Given this list of marker genes Dctn6, Fgd4 (FYVE, RhoGEF and PH domain containing 4), Hip1, Myo5b, Rasa1, Daam2, Cenph, Spta1, Plek2, Iqgap3, Macf1, Myoz2, Dvl1, Rapgef3, Ulk4, Arhgef5, Drg1, Ablim2, Dicer1, Pfdn1, Plekhh2, Krt33b, Grid2ip, Odad2, Myo1h, Cdc42bpb (NCBI Gene Id 93839), Dpysl2, Tln1, Agfg1, Flg, Dnal1, Mlst8, Pak1, Bcas3, Marcksl1, Kif3a, Krt23, Evl, Tubgcp2, Tbce, Arhgef10l, Zmym6, Nefm, Epha1, Mast1, Kif15, Sh3d19, Kank4, Agfg2, Nherf1, Jhy, Mcph1, Ttll6, Gas8, Bcl2l10, Haus8, Coro6, Map3k1, Brca1, Nectin2, Gan, Csf1r, Slc4a2, Cttnbp2, Lrrc23, Kiz, Bora, Map6d1, Nes, Actr3, Krt4, Thsd7a, Bbln, Kif2a, 4933427D14Rik, Cetn4, Lpar1, Tpm3-rs7, Obsl1, Stradb, Csf3, Arhgef17, Vim, Cdc42ep3, Cfap73, Atxn7, Pakap, Fgd1, Hepacam2, Cenpa, Brca2, Cep20, Ska1, Bcl6, Baiap2, Rsph6a, Meig1, Epb41l5, Sirt1, Efna5, Arrb1, Nme7, Dsp, Map1b, Cfap58, Cplane2, Ift88, Odam, Cdc20, Kash5, Cav1, Crk, Daw1 (dynein assembly factor with WDR repeat domains 1), Mei1, Kank2 (KN motif and ankyrin repeat domains 2), Eml3, Espnl, Srcin1, Id1 (inhibitor of DNA binding 1, HLH protein, NCBI Gene Id 98917), Ndc80, Fmnl2, Llgl2, Pxn, Dnaaf10, Capzb, Mtor, Lrch3, Uxt (NCBI Gene Id 319632), Haus5, Pex14, Stard8, Tubgcp6, Neb, Ccl24, Des, Epb41l4a, Arap3, Baiap2l2, Tuba1a, Limk1, Inpp5j, Eml1 (NCBI Gene Id 68519), Eps8, Pycard, Washc4, Stag2, Npm1, Ssh1, Fermt2, Sgo1, Mybph, Krt10, Actr2, Odf2, Tekt2, Pfdn2, Cdc14a, Prickle1, Antxr1, Smad4, Fchsd1, Rock2, Myo18b, Carmil1, Eef2k, Atat1, Fam107a, Rcc1, Lima1, Ccl12, Plk3, Shroom2, Tacstd2, Chd3, Gdpd2, Ccdc57, Rnd2, Rtkn, Hcls1, Srgap2, Dnaaf6rt (dynein axonemal assembly factor 6, retrotransposed), Gabarap, Rhobtb1, Htt, Ccdc61, S1pr2, Gm6176, Ttll5, Tenm1, Mapt, Mrtfa, Spata4, Arhgap17, Sptb (NCBI Gene Id 383567), Il1a, Tubgcp4, Dnaaf6 (dynein axonemal assembly factor 6), Sun1, Nckap5, Dlgap5, Myl9, Gm6882 (NCBI Gene Id 628475), Sh3gl2, Xpo1, Pls1, Chek1, Krt34, Arhgef10, Arhgap6, Pfn2, Krt26, Akap11, Pkp1, Kif20a, Poc5, Grhl3, Nebl, Pdgfrb, Prkn, Calml4, Naa20, Pof1b, Dsg3, Map3k20, Pierce1, Cfap44, Pla2g3, Fgf10, Pard3b, Lrrc61, Dnaaf11, Ccl7, Krt81, Lix1l, Ccn2, Auts2, Cx3cl1, Hsp90b1, Pdcl3, Ssh3, Spry2, Cdc42bpg, Fscn3, Casp4, Klhl24, Fgf7, Cc2d2a, Kank3, Tesk2, Cep250, Bag4, Elmod3, Hook2, Cryaa, Cep192, Tubb3, Strip2, Epb41l1, Bmerb1, Ccdc13, Cxadr, Smc3 (structural maintenance of chromosomes 3), Aqp2, Dmtn, Tuba1c, Myo1b (myosin IB), Prkaa2, 4930544G11Rik, Snx9, Tgfb1, Efhc1, Syne2, Nlrp5, Elmo1, Cdc42bpa, Ptk7, Add1, Epb41, Sh3pxd2b, Cd47, Mzt1, Myh11, Klhl41, Ablim3, Tnik, Actn1, Fgd2, Sik3, Dnai1, Chmp1b, Krt5, Sprr1b, Ccdc120, Larp4, Nudc, Cep19, Uvrag, Fam171a1, Fhdc1 (NCBI Gene Id 229474), Cflar, Icam1, Tsc1, Tubb5, Ptger4, Lrguk, Krt12, Ywhah, Diaph1, Whamm, Pik3r1, Gnai1, Chmp7, Map4, Taok2, Sapcd2, Stmn1, Abi2, Kirrel1, Abraxas2, Nav3, Amotl2, Capg, Fhod1, Lmod3, Ccnl1, Ccdc15, Ccdc40 (coiled-coil domain containing 40), Tchh, Diaph2, Cpne6, Cyfip2, Ccdc66, Akt1, Pik3r2, Tacc1, Sun2, Specc1l, Syde1, Raf1, Plekhg2, Gadd45a, Magel2, Tubal3, Mos, Crhr2, Krt13, Mypn, Ccdc39, Poldip2, Hook3, Tnnt3, Ccnl2, Dnaaf1, Cep43, P2rx7, Aqp1, Zmym4, Cep63, Dnaaf5, Nf2, Arhgef18, Gtf2b, Sprr2a1, Wnt4, Cfap74, Tubb1, Cc2d1a, Myo1a, Trdn, Smn1, Wipf3, Myo19, Cap2, Ccnb2, Dpysl3, Hmcn1, Hsph1, Ccnb1, Cdc42ep1, Rgs4, Krt42, Cenatac, Trpv4, Nlrp4f, Luzp1, Spag1, Tjp1, Rhoc, Krt82, Krt86, Gm14137, Krt71, Plk5, Cap1, Ngef, Arfip2, Syne3 (spectrin repeat containing, nuclear envelope family member 3), Emp2, Stmn2, Fbxw5, Gpr65, Epha3, Gja1, Phldb2, Naa25, Msrb1, Ppfia1, Lrrc46, Diaph3, Prr5, Ska2, Axin1, Jmy, Abraxas1, Cfap206, Pdgfa (platelet derived growth factor, alpha), Cfap100 (NCBI Gene Id 77534), Elmo2, Parvb, Phactr2, Abra, Arfgef1, Knstrn, Phip, Arhgap12, Tmod2, Mtm1, Mical3, Tgfbr1, Spata7, Kif2c, Mylk3, Map7d2, Cdc20b, Mdk, Myo7a, Krt39, Spaca9, Dnai3, Atf5, Frmd5, Katnal2, Ino80, Poc1b, Map7d1, Rnf4, Iqsec1, Mapre3, Hras, Plek, Stau2, Sptbn1, Krt78, Pacsin1, Fhod3, Trf, Cln3, Limd2, Eml4, Prune1, Brsk1, Tppp, Mybl2, Wipf1, Pkp2, Casq1 (NCBI Gene Id 12372), Apc, Krt17 (NCBI Gene Id 16667), Ntmt1, Ckap2, Ubxn2b, Ttll8, Ankfn1, Tacr1 (NCBI Gene Id 21336, tachykinin receptor 1), Krt28, Smad3, Wee1, Rac1, Haus2, Atp2c1, Swap70, Slc39a12, Arpc1a, Kifc5b, Limd1, Cep44, Prex1, Nuak2, Arc, Ccl21a, Rap1gds1, Armc2, Tppp3, Ccr7, Baiap2l1, Cdk11b, Cdk2ap2, Chmp1b2, Cep85, Cfap91, Mid1ip1, Hnrnpu, Zmym3, Dst, Thy1, Nsfl1c, Zfp207, Frmd7, Pafah1b1, Cep126, Cdc42ep5, Cgnl1, Wtip, Ttc8, Cltc, Abi3, Agap2, Tmeff2, Ift56, Iqgap1, Csnk1a1, Prkcd, Akap9, Incenp, Cep295nl, Gas2, Specc1, Myo3a, Ttll11, Arhgef19, Epb41l2, Atxn3, Prkce, Pacsin3, Dnai4, Ect2, Myo1f, Kit, Ikbkb, Brsk2, Xirp2 (xin actin-binding repeat containing 2), Septin7, Ttll2, Cdc14b, Arpin, Rictor, Cul7, Wasl, Afg2b, Nefh, Cenpe, Pard6g, S1pr1, Bnip2, Krt74, Ctnnb1 (NCBI Gene Id 12387), Samd14, Zyx, Nckap1, Bcar1, Clasp2, Golga2, Rala, Zranb1 (NCBI Gene Id 77556), Cryab, Apc2, Git1, Kif21a, Myo6, Snupn, Itgb1bp1, Dnah5, Krt7, Pkp3, Wnt11, Pam, Krt25, Eppk1, Washc5, Limk2, Atp8a2 (NCBI Gene Id 50769), Krt72, Tubd1, Pard6a, Ccdc68, Tmem67 (NCBI Gene Id 76678), Scin, Clasp1, Pak5, Map7, Cldn3, Rhoq, Itgb3, Wmp, Wnt3a, Mast2, Bcr, Kras, Kif11, Plec, Bfsp1 (NCBI Gene Id 277454), Adgrb1, Nphs2, Zw10, Tbc1d32, Cald1, Cavin3, Zmynd12, Crocc, Ccdc69 (coiled-coil domain containing 69), Gapdhrt2 (glyceraldehyde-3-phosphate dehydrogenase, retrotransposed 2), Cracd, Myom1, Pak3, Cep290, Flnc, Ak7, Wasf1, Xrcc2, Sirpa, Krt40, Dag1, Pard6b, Pkhd1, Togaram1, Ripor2, Kif3b, Katnbl1, Sass6, Enkd1, Arpc1b, Nisch, Ppm1f, S100a10, Tbck, Mfn2, Stag1, Mast3, Cetn2, D7Ertd443e, Arpc5l, Kat2a, Chordc1, Gm10668, Mkks, Spice1, Mapk15, Kat5, Lurap1, Capn6, Prkar1a, Carmil3, Pawr, Prkcz, Pax6, Nedd9, Epha5, Cep120, Sbds, Arf6 (NCBI Gene Id 11845), Arap1, Spast, Flii, Ttll9, Actb (actin, beta), Arhgap35, Rufy3, Sh2b2, Eml2, Inf2, Prph, Ooep, Sugt1, Dcx, Tuba3a, Cdk5r1, Ccdc42, Mtpn, Capn1, Dixdc1, Pierce2, Son, Kiss1r, Dync1li2, Gda, Aurkc, Myh14, Pdlim3, Nexn, Spatc1l, Ccl21d, Apoa1, Znrf1, Enah, Mef2c (myocyte enhancer factor 2C), Jam3, Kifbp, Gm5478 (predicted pseudogene 5478), Cfap43, Lzts2, Poc1a, Sh3bgrl3, Myh9, Arhgef1, Arhgef16, Mns1, Mapre2, Catip, Nup62, Svil, Gapdhrt, Clip2, Gas2l2 (NCBI Gene Id 278498), Bcl2, Actn2, Spire2, Prpf40a, Was, Atrx, Sac3d1, Dynlt1f, Cfap65, Anxa1 (annexin A1), Lmod1, E2f4, Fsip1, Cfap410, Cep135, Capza1b, Shank3 (NCBI Gene Id 58234), Ttl, Capza2, Arap2, Adprhl1, Numa1, Slc16a1, Fbxo5, Rae1 (NCBI Gene Id 66679), Trim37, Tspan32, Cav3, Kank1, Hck, Tacc3 (transforming, acidic coiled-coil containing protein 3), Arhgap25, Actn4, Fhl3, Ush1c, Kifc1, Cript, Arhgap40, Prkcq, Fgr, Cul9, Pfn1, Tesk1, Cntln, Phldb1, Gmfb, Add3 (adducin 3), Abl2, Edn1, Sfrp1 (NCBI Gene Id 72362), Ska3, Nat10, Tacc2, Lsm14a, Rp1, Capn10, Chmp2b, Fgf13, Pgm5, Cdk10, Sorbs1, Atf2, Cep295, Odad1, Hook1, Cavin4, Spef2, Zbed3, Septin1, Spc25, Zpr1, Arf1, Fitm2, Ppl, Gm10662, Ttll7, Myo7b, Dnah7c, Cdk1, Cetn1, Kif18a, Cyld, Chmp4c, Palld, Ccdc187, Cgn, Wasf2, Mecp2, Ube2b, Krt36, Wdr47, Lpin1 (NCBI Gene Id 50494), Rhov, Nusap1, Msrb2, Nde1, Bcas2 (NCBI Gene Id 99556), Inpp5k, Fkbp4, Smc1a, Tnfaip1, Cep152, Llgl1, Dnaaf4, Ezr, Pdxp, Abr, Map2, Large1, Usp33, Nox4, Sod1, Tubg1, Limch1, Haus4, Rps3, Map7d3 (NCBI Gene Id 320923), Cep131, Tube1, Arhgef15, Itgb1, Misp, Sema5a, Pmp22, Padi6, Tnf, Lmna, Cnn2, Ccl26 (NCBI Gene Id 541307), Fam83h, Ccser2, Micall2, Cd2ap, Arfip1, Pten, Pdgfra, Stmn3, Twf2 (twinfilin actin binding protein 2), Cntrob, Pkd1, Tpm3, Amot, Avil, Dstn, Nkx2-5, Fscn1 (fascin actin-bundling protein 1), Ccdc78 (NCBI Gene Id 381146), Actc1, Aif1, Gsk3b, Cntn2, Krt35, Mlh1, Phactr3, Fgd3, Fbxo24, Rhob, Fscn2, Krt77, Dnah7a, Maea, Cldn19, Ccl21b, Sox9, Tubgcp3, Tlr2, Pclo, Myo5a, Mapk1, Itpka, Fzd10, Vil1, Cln8, Krt84, Dctn2, Ints13, Cep72, Dnah8, Ccdc88a (NCBI Gene Id 77927), Tmsb15b2, Ehd2, Mir129-2, Pdzd8, Pcm1, Cdk5r2, Spag17, Arpc5, Parvg, Celsr1, Haus7, Trpm7, Rhoa, Rab13, Farp1, Tmod1, Serpinf2, Slain2, Ugt8a, Setd3, Cdc42ep2, C2cd3, Ablim1, Stmn4, Ppp2r1b, Pdcl2, Cep70, Synpo2l, Myo1c, Nlgn1, Tuba4a, Synpo2, Cul3, Mark2, Sdccag8, Cntnap1, Bbs1, Esam, Odad3, Calm4, Nck1, Pdlim4, Gpsm1, Kif23, Kif4, Mtcl1, Stk36, Gcc2, Pip5k1a, Neurl2, Senp6, Myh10, Rhog, Cfap157, Ssx2ip, Krt6a, Agrn, Ccl27a, Tubb4b, Gfap, Cfap69, Shc1, Chmp2a, Dnah7b, Rgcc, Tubb4a, Katnb1, Tubb2b, Dcaf13, Gpsm2, Vps4b, Epb41l3, Ptpa, Camsap1, Mad2l2, Eln, Tnnt1, Sgk1, Bin1, Racgap1, Wasf3, Pdgfb, Rac3, Fat1, Uhrf1, Rhoj, Ccnf, Tac1, Myl2, Kif18b, Nrp1, Hax1, Fsd1, S100a9, Stil (NCBI Gene Id 230631), Cep350, Krt87, Clec2i, Cit, Ccdc88c, Rhobtb2, Mark3, Shtn1, Ppp2r3c, Ttc12, Bbs2, Trim36, Spire1, Lsp1, Evpl, Nck2, Cfap57, Acta1, Map9, Cdkn1b, Hoatz, Efcab11, Disc1, Ccl21e, Drc7, Clip3, C9orf72, Fchsd2, Dapk3, Ank3, Wdr73, Stard13, Rgs14, Rock1, Ina, Chmp6, Arhgef2, Grb2, Krt75, Plk4, Itgb1bp2, Tle6, Rdx, Farp2, Tpm2, Aspm, Fer, Abitram, Pick1 (NCBI Gene Id 18693), Fam110a, Drc1, Myo1e, Slain1, Arl2, Synpo, Actn3, Ndel1, Bmp10, Hydin, Xirp1 (xin actin-binding repeat containing 1), Myoz1, Brk1, Chp1, Dynlt1b, Krt32, Mark1, Shank1, Cep68, Iqsec3, Ajuba, Vangl2, Spag16, Azin1, Dynlt1c, Chmp5 (NCBI Gene Id 76959), Myo18a, Mob2, Camsap2, Krt16, Spag5, F2rl1, Akap13, Xrcc3, Spef1l, Sorbs3, Daam1, Gm5890, Trpv3, Nckap1l, Add2, Ss18, Map1a, Met, Csrp3, Inppl1, Myh6, Wdr1, Pik3ca, Septin9, Ppfibp1, Pibf1, Arhgap28, Dnai2 (NCBI Gene Id 432611), Cdk5rap2, Csrp2, Gas2l1, Gba2, Pls3, Krt18, Krt31, Vps54, Hdac6, Fsip2, Hspa1b, Ssh2, Hdac3, BC034090 (NCBI Gene Id 207792), Ptk2b, Rnd3, Cobl, Gpr35, Pfn5, Dyrk1a, Sptbn2, Asb2, Ccdc65, Coro1b, Krt1, Prkci, Mapk8, Haus6, Mapre1, Nav1, Nos1ap, Pdcd6ip (programmed cell death 6 interacting protein), Rp1l1 (NCBI Gene Id 613256), Gsn, Mycbp2, Haus3, Dock2, Smap1, Foxj1, Prkaa1, Cdk5, Ccdc103, Shh, Chmp4b, Kat2b, Tnnt2, Epb41l4b, Gpm6b, Tln2, Ghrl, Rsph9, Mical1, Sipa1l1, Twf1, Arhgef7, Naa80, Krt83, Dctn1, Map6, Spry1, Phactr1, Tuba8, Cdh5, Hspa1a, Haus1, Tbcel, Bicd1, Ccp110, Pard3, Rap2a, Cnn3, Abl1, Kcnc3, Pdlim5, Tagln2, Pdlim1, Sh3d21, Gas7 (NCBI Gene Id 320013), Nuf2, Abi3bp, Ranbp10 (RAN binding protein 10), Sptbn4, Traf3ip1, Kif19a, Iqsec2, Braf, Katnal1, Birc5, Cotl1, Parva (NCBI Gene Id 76528), Loricrin, Ckap5, Krt9, Rflnb, Mdm1, Pdlim2, Camsap3, Nubp1, Krt2, Ccdc63, Amotl1, Cenpj, Capn3, Cdc42ep4, Tuba1b, Dync1h1, Sptan1, Fmnl3 (formin-like 3), Ankrd53, Rnh1, Mrtfb, Krt33a (keratin 33A), Krt15, Mapk3, Cyfip1, Ranbp1, Washc3, Ep300, Mink1, Dzip1, Pcdh15, Rho, Plxna3, Pfn3, Prkd1, Ccl3, Parp3, Nedd1, Tmsb10 (thymosin beta 10), Iqcg, Clip1, Pi4ka, Espl1, Prox1, Stmnd1, Flnb, Rsph1, Ap1ar, Wrap73, Neurl1a, Aurkb, Arpc3, Spag6, Ddb1, Washc1, Ttll1, Espn, Lmnb2, Ptpn1, Ctnna2, Ppp2r1a, Alkbh4, Bbs4, Mast4, Tubg2, Gsk3a, Gm28729, Dclk2, Pcnt, Bst1, Bicd2, Katna1, Ppargc1b, Tgfb3, Capza1, Itgb5, Myadm, Mad2l1, Lrp1, Dnaaf3, Rbm14, Kif24, Aaas, Taok1, Tor1a, Cyria, Kctd13, Asap3, Prickle4, Tmsb4x, Trim46, Tbcd, Bbof1, Dtnbp1, Hrg, Myo5c, Rac2, Tgfb2, Rhou, Sptbn5, Ccdc88b, Alms1 (NCBI Gene Id 381791), Six4, Krt19, Rhoh, Cluap1, Synm, Trim32, Mical2, Ppp1r9b, Tagln3, Krt20, Rsph4a, Ttll13, Fmn1, Nefl, Dlc1, Tubb2a, Vcp, Trpm2, Anln, Timd4, Gas2l3, Calr, Ccsap, Cdh1, Ranbp9, Spef1, Mef2a, Mkln1, Nf1, Calm5, Mcidas, Rhod, Aif1l, Tmod3, Ftcd, Tcap, Coro7, Vasp, Zeb2, Siglec15, Rflna, Kif14, Chmp1a, Bloc1s6, Map10, Pclaf, Togaram2, Actg1, Krt8, Map1s, Cep76, Arhgap44, Vill, Marcks, Txndc9, Rttn, Khdc3 (KH domain containing 3, subcortical maternal complex member), Mybpc2, Psrc1, Tpgs1, Ermn (NCBI Gene Id 99121), Hdac2, Frmd3, Mybpc3, Dnm2, Cep97, Krt85, Ppm1e, Smim22, Ttn, Wdpcp, Tpm4, Ncor1, Pstpip2, Dnajb13, Spag6l, Dchs1, Ankrd23, Pecam1, Krt80, Alox15, Ccdc170, Gapdh, Src, Ldb3, Nckap5l, Ilk, Cnn1, Zmynd10, Hdgfl3, Myo1g (myosin IG), Phpt1, Krt79, Cdca8, Ttc17, Cdk2, Nin, Lcp1, Frmpd4, Shroom4, Dnajb6, Krt24, Nrap, Ccl11, Ran, Tpm1, Ccl21f, Gm4513, Cyrib, Fignl2, Tpr, Casq2, Krt6b, Coro1a, Myom2, Strip1, Trim27, Setd2, Capza3, Deup1, Sh3bp1, Shroom3, Tubb6, Cspg5, Washc2, Clxn, Ift46, Carmil2, Htr1a, Odad4, Gm5157, Csrp1, Myo1d, Nek2, Wdr62, Rnd1, Plk1, Snca, Tyrobp, Dnaaf2, Myoc, Dnah17, Fmnl1, Ttbk2, Clip4, Tbc1d21, Pde4dip, Cfap47, Ang (angiogenin, ribonuclease, RNase A family, 5), Clrn1, Dock7, Iqgap2, Flna, Ccnb1-ps, Fes, Myom3, Wdr90, Ccdc8, Ift172, Gmfg, F11r, Stard9, Tmod4, Aunip, Thsd7b, Rhpn2, Lats1, Tpx2, Shroom1, Ppp1r35, Snhg15, Arhgap10, Coro1c, Kif2b, Mark4, Mtss1, Kptn, Krt73, Aurka, Csnk1d, Sipa1l3, Cfap97d1 (NCBI Gene Id 75437), Krt90, Bfsp2, Tnfaip3 (tumor necrosis factor, alpha-induced protein 3), Cttn, Tmsb15l, Chmp3, Brwd3, Rab11a, Dbn1, Bccip, Ssna1, Dynlt1a, Lmod2 (leiomodin 2 (cardiac)), Dnah1, Cetn3, Ppp1r9a, Krt27, Mybpc1, Dreh, Gen1, Ptk2, Tubgcp5, Iqschfp, Kpnb1, Gm5414, Tppp2, Pdlim7, Tagln, Spdl1, Ghsr, Trim54, Plk2, Ninl, Arhgef26, Ttll4, Mapkap1, Myo3b, Plxnb1, Srf, Cib1, Mid1, Phactr4, Ttll3, Wdr72, Arpc2, Pak2, Slk, Fmn2, Elmo3, Dnah2, Brwd1, Arpc4, Sh3kbp1, Insrr, Cdc42, Prc1, Ophn1, Pacsin2 (protein kinase C and casein kinase substrate in neurons 2), Arhgef28, Palm, Rhpn1, Arhgap18, Krt14, Krt76, Sdc4, Rangrf, Coro2b, Chek2, Klhl17, Slit2, Dbnl, Ppp1r12a, Rhof, Tbcb (tubulin folding cofactor B), Dync1li1, Bst2 (bone marrow stromal cell antigen 2), Cfl2, Cfl1, Hip1r, Dlg1, Myo15a, Ofd1, Nphs1, Fbxw11, Kbtbd13, here is a description of the gene set: studied in species Mus musculus A process that is carried out at the cellular level which results in the assembly, arrangement of constituent parts, or disassembly of cytoskeletal structures. Mouse Gene Set: GOBP_CYTOSKELETON_ORGANIZATION